The following is a description of a gene set: Any process that activates or increases the frequency, rate, or extent of myeloid leukocyte mediated immunity. species: Homo sapiens Human Gene Set: GOBP_POSITIVE_REGULATION_OF_MYELOID_LEUKOCYTE_MEDIATED_IMMUNITY, and this is the list of marker genes: POMC, DDX21, DHX36, FCGR1A, F2RL1, STX4, ITGAM, MAVS, SPI1, ARG1, HLA-E, RIGI, TICAM1, STAP1, CAMK4, BTK, C3, ITGB2, DDX1, TYROBP, FCER1G, CD177